The following is a description of a gene set: A constituent of the extracellular matrix that enables the matrix to resist longitudinal stress. studied in species Homo sapiens Human Gene Set: GOMF_EXTRACELLULAR_MATRIX_STRUCTURAL_CONSTITUENT_CONFERRING_TENSILE_STRENGTH, and this is the list of marker genes: COL4A3 (collagen type IV alpha 3 chain), COL7A1, COL12A1, COL5A1, COL9A1, COL2A1, COL16A1, COL17A1, COL11A1, COL4A2, COL6A2, COL14A1, COL19A1, OTOL1 (otolin 1), COL28A1, COL8A1, COL4A5, COL21A1, COL4A4, COL6A5, COL3A1, COL23A1 (collagen type XXIII alpha 1 chain), COL1A2, COL5A2, COL4A1, COL6A6, COL4A6, COL10A1, COL15A1, COL6A3, COLQ (collagen like tail subunit of asymmetric acetylcholinesterase), COL25A1, COL18A1, COL9A2, COL11A2, COL8A2, COL5A3, COL6A1, COL9A3, COL22A1, COL13A1, COL27A1, COL1A1, COL24A1